Given this list of marker genes MSH6, RPA1, SSRP1, RAD21, PRPSAP1, CCT5, SSBP1, PSMB2, USP1, HNRNPA2B1, RFC4, G3BP1, HDAC2, UNG, BUB3, CLNS1A (chloride nucleotide-sensitive channel 1A), EIF2B4, HAT1, SMC1A, MCM2, AIMP2, PCNA, IARS1, DEK, COPS5, RANBP1, SUCLA2, SRSF1, ATP5PF, ZZZ3, NUDC, POLR2I, XPO1, TRRAP, POP5, ILF2, RUVBL2, NAE1, ALG8, DDX39A, NUP188, LRPPRC, MSH2, SNRNP200, GTF2H1 (NCBI Gene Id 2965), CHAF1A, SPCS2, GPN1 (GPN-loop GTPase 1), ACTL6A, METAP1, MRPS18B, HNRNPU, RRM1 (ribonucleotide reductase catalytic subunit M1), KHDRBS1, HNRNPAB, PARG, ICE1, SET, SOD1, BAZ1B, SART3, here is a description of the gene set: species: Homo sapiens Neighborhood of MSH2 mutS homolog 2, colon cancer, nonpolyposis type 1 (E. coli) in the MORF expression compendium Human Gene Set: MORF_MSH2 Neighborhood of MSH2